Given this list of marker genes HSF4, FEV, ABAT, DVL1, CTF1, NNAT, P2RX1, MR1, KCNJ4, CYP2F1, SLA, CCL2, SLC30A3, TBXA2R, POLA2, EFNA3, CD34, CSRP3, TNR, CNTN1, SLC5A2, PRB4, FGR, ADCYAP1, RAPGEF5, CLCNKA, GNA15, AZGP1 (NCBI Gene Id 90053), MEF2C, SPTB, MLANA, CYP2A6, LIF, FUT3, ZP2, IGHMBP2, CALB2, RGS16, KRT86, SPRR2C, MME, TBR1, PTPRU, SLC18A1, VAV2, ZNF143, NR1D1, ZNF157, PROC, DPEP1, OAS2, CD8B, PDE4A, MPP3, GMPR, STAT4, MPP2, HLA-DOB, ZKSCAN7, RCAN2, TUB, CD33, AIF1, STXBP1 (NCBI Gene Id 6812, syntaxin binding protein 1), ATP6V1B1, FLT1, TAF1, RASL10A, ARHGAP4, IRF5, DLG4, KRT31, CEACAM4, CHRNE, MYOG, NHERF2, KDM5D, NTN3, WNT10B, PHKG1, KRT6A, KRT33B, ITIH4, MYBPC1, FUT7, PAX8, PTPRN, AFAP1, ATF6B, PSD, GNG4, MPZ, S100P, GRM4, MYBPC2, NOS1, EDEM1, CFB, SMPDL3B, AVPR1B, CHI3L2, GOLGA1, CD22, KRT2, MVK, IL2RG, PFKFB3, SLC6A9, here is a description of the gene set: studied in species Homo sapiens Human Gene Set: MODULE_157 Genes in the cancer module 157.